The following is a description of a gene set: from publication Mense SM, Sengupta A, Zhou M, Lan C, Bentsman G, Volsky DJ, Zhang L (PMID 16507782) studied in species Homo sapiens Hypoxia response genes up-regulated in both astrocytes and HeLa cell line. Human Gene Set: MENSE_HYPOXIA_UP Oxygen is vital for the development and survival of mammals. In response to hypoxia, the brain initiates numerous adaptive responses at the organ level as well as at the molecular and cellular levels, including the alteration of gene expression. Astrocytes play critical roles in the proper functioning of the brain; thus the manner in which astrocytes respond to hypoxia is likely important in determining the outcome of brain hypoxia. Here, we used microarray gene expression profiling and data-analysis algorithms to identify and analyze hypoxia-responsive genes in primary human astrocytes. We also compared gene expression patterns in astrocytes with those in human HeLa cells and pulmonary artery endothelial cells (ECs). Remarkably, in astrocytes, five times as many genes were induced as suppressed, whereas in HeLa and pulmonary ECs, as many as or more genes were suppressed than induced. More genes encoding hypoxia-inducible functions, such as glycolytic enzymes and angiogenic growth factors, were strongly induced in astrocytes compared with HeLa cells. Furthermore, gene ontology and computational algorithms revealed that many target genes of the EGF and insulin signaling pathways and the transcriptional regulators Myc, Jun, and p53 were selectively altered by hypoxia in astrocytes. Indeed, Western blot analysis confirmed that two major signal transducers mediating insulin and EGF action, Akt and MEK1/2, were activated by hypoxia in astrocytes. These results provide a global view of the signaling and regulatory network mediating oxygen regulation in human astrocytes, and this is the list of marker genes: RBPJ, NDRG1, THAP8, ZBTB25, GPI, LINC00938, CTTN, GNA13, FAM13A, SLC2A3, HK2, KDM4C (lysine demethylase 4C), ANKRD37, DIDO1, PEX13, ASPH, SCD, INSIG2, ELL2, GADD45A, ENO2, BHLHE40, KLHL24, PPP1R3C, STC2, ABCB6, NOL3, KIAA2013, MIR210, PGK1, PPFIA4, NFIL3, PFKFB4, PRPSAP1, PLOD2, FAM110C, ATF3, KLF7, KLF4, ENSG00000291149, SOD2, OSMR, KDM3A, MXI1, SERGEF, STK4, HILPDA, SPAG4 (NCBI Gene Id 6676), P4HA1, ADM, RNASE4, RIOK3, MED6, BNIP3L, VEGFA, CLK3, GPRIN3, STARD4, CDK19, KDM4B, DPCD, PPP1R15A, BHLHE41, ERICH1, ERO1A (NCBI Gene Id 30001), RORA, INSIG1, TC2N, FOXD1, CEBPB, PDK1, PLIN2, ALDOC, EGLN1, LCORL, C4orf3, BNIP3, HCFC1R1, TIPARP, MAFF, PFKFB3, LARP6, TMEM65, CLPB, P4HA2, WDR54, NAMPT, LOX, ANGPTL4, FAM162A, JMJD6, PRELID2, NADSYN1, FUT11, ANG (angiogenin), TSLP, GBE1, EEF1AKMT3, CEBPD, GOSR2